The following is a description of a gene set: Protein folding. studied in species Homo sapiens Human Gene Set: MODULE_355, and this is the list of marker genes: DNAJA1, HSPA5, HSPB1, HSPE1, HSPD1, CCT6A, CDC37, HSPA8, DNAJB2, HSPA1L, LRPAP1, CCT2, HSP90AB1, HSP90B1, BAG3, HSPA6, DNAJB1, CRYAB, HSPB2, BAG1, TRAP1, CANX, URI1, CCT8, COX17, TSC2, FKBP4, TBCA, PPIA